The following is a description of a gene set: Reactome Pathway: Signaling downstream of RAS mutants Disease-causing mutations in RAS favour the active RAS:GTP bound form and yield constitutively active forms of the protein. Mutations in RAS contribute to cellular proliferation, transformation and survival by activating the MAPK signaling pathway, the AKT pathway and the RAL GDS pathway, among others studied in species Homo sapiens part of: Signaling by RAS mutants, and this is the list of marker genes: ACTB, RAF1, YWHAB, FGA, RAP1A, ARRB1 (arrestin beta 1), RAP1B, PHB1, MARK3 (microtubule affinity regulating kinase 3), MAPK3, MAPK1, PEBP1, SRC, CAMK2D, BRAP, ITGA2B, CALM1, MAP3K11, FGB, TLN1, BRAF, CNKSR1, ARAF, JAK2, IQGAP1, VCL, MAP2K1, CAMK2B, MAP2K2, KSR2 (kinase suppressor of ras 2), ITGB3, KSR1, CSK, NRAS (NCBI Gene Id 4893, NRAS proto-oncogene, GTPase), VWF, ARRB2, FN1, ACTG1, CAMK2G, APBB1IP, KRAS, CNKSR2, FGG, CAMK2A, HRAS (HRas proto-oncogene, GTPase)